The following is a description of a gene set: species: Homo sapiens Human Gene Set: WP_CAMKK2_PATHWAY CAMKK2 pathway, and this is the list of marker genes: TSPAN8, CPOX, SLC25A21, CDC25A, DNM1L, S100A8 (NCBI Gene Id 6279), MS4A3, CD28, CAMK4, TBXT, CTSE, SIRT1, IFI44L, ABCA1, CAMK1, GIT1, PFKFB3, SELL, MAP1LC3A, KLF1, CRTC2, MAMDC2, SFI1, PFKFB2, WDR35, RASGRP1 (RAS guanyl releasing protein 1), CCR9, HDAC4, SLC38A5, NEDD4L, ERMAP, GATM, TSC1, MAPK3, NOS1, CHRM3, PCK2, SLC2A4, SPINT1, MAP1LC3B, CXCL11, TMEM176B, VCAM1, AHSP, RHAG, HMBS, MTOR, PLAC8, SQSTM1, ASNS, ATP1B2, IRGC, RPTOR, FAM20C, SPIRE1, RPS6, CDH1, RAF1, NFE2L2, GALNT9, PAK1, TNF, TRPV4, HMOX1, RHD, ARHGEF7, HK2, FIS1, C1QTNF12, MAPK1, STIM1, KDR, CAMKK2 (NCBI Gene Id 121657), PARP1, SREBF1, ENHO, NFATC2, IL15, SMC1A, MID1, ULK1, OASL, CCND1, HK1, CCNE1, HFE, ICAM1, ACACA, CCL5, GCK, EPOR, CALM1, NLRP1, MX2, CYB5R3, AQP1, TSPAN33, RPS6KB1, SLC2A1, MAF, RELA, FASN, SLCO3A1, HIF1A (hypoxia inducible factor 1 subunit alpha), CREB1, RAC1, WFS1, ATP10D (NCBI Gene Id 57205), EP300, KEAP1